The following is a description of a gene set: studied in species Homo sapiens Human Gene Set: GOBP_LYMPHOCYTE_HOMEOSTASIS The process of regulating the proliferation and elimination of lymphocytes such that the total number of lymphocytes within a whole or part of an organism is stable over time in the absence of an outside stimulus., and this is the list of marker genes: SKIL, TNFRSF13B, IL20RB, SPTA1, CD74, PPP3CB, SPNS2, CAMLG, SOS1, SLC46A2, BBIP1, GPAM, TSC22D3, SLC39A3, PPP2CA, SIT1, GPR174, SH2B2, LMO1, NCKAP1L, BCL2, MIF, ZC3H8, AKT1, TNFRSF17, FOXN1 (NCBI Gene Id 8456), MEF2C, PPP2R3C, JAK3, TGFB2 (transforming growth factor beta 2), LGALS9, TNFSF14 (TNF superfamily member 14), IL2RA, MIR17HG, LYN, DOCK11, IL7R, STAT5B, PRDX2 (peroxiredoxin 2), CCNB2, PPP2R1A, CHST3, FOXP3, WDR37, RAG1, SASH3, P2RX7, ADA, PMAIP1 (NCBI Gene Id 9305), LAT, GAPT (NCBI Gene Id 202309), BAX, TNFSF13B, SOS2 (NCBI Gene Id 96829), TRAF3IP2, PACS1, BBS4, DOCK10, TNFAIP3, AIM2, DNAJA3, TGFB1, RC3H2, SIVA1, HIF1A, IKBKG, GPR15LG, IL2 (NCBI Gene Id 3558), LGALS2 (NCBI Gene Id 3957), BCL2L11, RIPK3, RC3H1, SLC40A1, BAK1, CASP3, ABL1, STAT5A (NCBI Gene Id 6776), FADD, BCL10, FAS, CORO1A, TCIRG1, PKN1